Given this list of marker genes CHMP2B, CHMP4C, CHMP4B, CHMP6, UVRAG, CHMP3, BECN1, CHMP4A, CHMP7, MAP1LC3B, PIK3R4, CHMP2A, ISCU, PIK3C3, here is a description of the gene set: Translation of Replicase and Assembly of the Replication Transcription Complex studied in species Homo sapiens Human Gene Set: REACTOME_TRANSLATION_OF_REPLICASE_AND_ASSEMBLY_OF_THE_REPLICATION_TRANSCRIPTION_COMPLEX